The following is a description of a gene set: Mouse Gene Set: chr13D2 studied in species Mus musculus, and this is the list of marker genes: Gm8990, Mier3, Gm9752, Il6st, Gm18883, Gm41077, 4930526H09Rik, Gm32090, Itga2, Gm20900, Gm15285, Cspg4b, Ipo11, Tcstv6b, Tcstv2b, Gm9633, Tcstv1b, Tcstv2a, Gm24527, Gm21370, Tcstv7a, 4930544M13Rik, 3830408C21Rik, Dimt1, Gm26349, Tcstv6a, Gm2822, Gm15327 (NCBI Gene Id 100504675), Gm31104 (NCBI Gene Id 102633222), Gm10732, Fst, Tcstv5a, Esm1 (endothelial cell-specific molecule 1), 3110015C05Rik, Gm31191, Gm20784, Ccno, Gm15326, Hspb3, Slc38a9, Gm29767, Paip1, AI197445, Snx18, Gm15286, Plk2, Gm5455, Anxa2r1, Gm6416, Hmgcs1 (NCBI Gene Id 208715), 1700084D21Rik, 1700006H21Rik, Gm30747, Ndufs4, B430218F22Rik, Gm10736, Gm6270, Lrrc70, Gm15323, Smim15, Ankrd55, Mtrex, Gm21358, Mcidas, Zswim6, Gm18135, Gm18759, 1700074H08Rik, Gm15322, Gm17509, Gm16263, Hcn1, Pelo, Nnt, 4921509O07Rik, Gm29764, B230220B15Rik, Depdc1b, 2810403G07Rik, Gm32004, Gm34586 (NCBI Gene Id 102637890), 1700003P14Rik, Gm32376, Zfp131, Gm10734, Gm6035, Tmem267, Tcstv3, Gm48026, Gm18945, Gm21181, Tcstv1a, Kif2a, Mrps30, Mir449a, Setd9-ps, Rps3a3, Gm30839, Isl1, Nim1k, Gm6421, Tcstv2c, Mir449b, Gapt, Gpbp1, Gpx8, Rpl34-ps2, Gm36161, Gm41073, Anxa2r2, Plpp1, Gm30411, Gm2726, Ddx4, Gm8795, Itga1, Fgf10, Gzmk, Gm33045, Dhx29, Parp8, Ndufaf2, Rab3c, Gm34471, Mir1904, Arl15, Ccl28, Gm6343, Elovl7, Il31ra, Pde4d (phosphodiesterase 4D, cAMP specific), Gm38397, Gm31544, Gm41071 (NCBI Gene Id 105245643), Cdc20b, Gm2736, Gm10735, Ncf2-rs, Map3k1, Gm15325, 4933413L06Rik, Gm48837, 3110070M22Rik, A430090L17Rik, Gm33172, Gm3226, 4833420G17Rik, Ercc8, Emb, Gm20763, Gm21378, Gm47335, Gm5200, Mir582, Gm18361 (NCBI Gene Id 100417013), Mocs2, Mir449c, 4631422I05Rik, 4930435F18Rik, Actbl2, Gzma, Gm15290, 4930467J12Rik, Gm9098, Gm20769, Apoo-ps, 4930563N14Rik, Tcstv4